Given this list of marker genes CAT, STOX1, MT-TQ, HLA-DQB1, TTC7A (NCBI Gene Id 57217), DUT, MT-ND1, HNF1A, GCK, TCF4, IL18BP, TLR8, EDA, MT-CO2, MT-ND4, GPR35, SEMA4D, HR, MIA3, MT-ND5, MT-TL1, IL2RA, SPI1, CORIN, MT-TH, GFM2, AIRE, MT-CO1, CAV1, CTLA4, ITCH, CNOT1, DNASE2, EIF2AK3, SLC29A3, CBLB, ABCC8, EDA2R, MT-TS2, MMP14, HLA-DQA1, MT-CO3, INS, MST1, KCTD1 (NCBI Gene Id 284252), SLC37A4, MT-TW, SLC12A3 (NCBI Gene Id 6559), STUB1, CLCNKB, LRBA, PDCD1, MT-ND6, DNAJC3, STAT3, GOSR2, FOXP3, MT-TF, STAT1, KCNJ11, MMP2, NAF1, PI4KA, ADA2, DMXL2, NEUROG3, TKT, MT-TE, PSTPIP1, FLT1, here is a description of the gene set: Human Gene Set: HP_TYPE_I_DIABETES_MELLITUS A chronic condition in which the pancreas produces little or no insulin. Type I diabetes mellitus is manifested by the sudden onset of severe hyperglycemia with rapid progression to diabetic ketoacidosis unless treated with insulin. studied in species Homo sapiens Type I diabetes mellitus